Given this list of marker genes Sqstm1, Dio3, Ceacam2, Atf2, Fgf16, here is a description of the gene set: The multiplication or reproduction of brown fat cells by cell division, resulting in the expansion of their population. A brown fat cell is a fat cell found the thermogenic form of adipose tissue found in newborns of many species. studied in species Mus musculus Mouse Gene Set: GOBP_BROWN_FAT_CELL_PROLIFERATION